Given this list of marker genes UBA52, LIG1, RFC4, RFC3, POLD1, RPA1, XRCC1, UBC, POLE3, POLD4, RPA2, POLK, POLE4 (NCBI Gene Id 56655), RPS27A, PCNA, RFC1 (NCBI Gene Id 5981, replication factor C subunit 1), UBB, POLE, RPA3, POLD2 (NCBI Gene Id 5425), RFC2, POLD3, POLE2, RFC5, LIG3, here is a description of the gene set: Reactome Pathway: Gap-filling DNA repair synthesis and ligation in GG-NER species: Homo sapiens part of: Global Genome Nucleotide Excision Repair (GG-NER) Global genome nucleotide excision repair (GG-NER) is completed by DNA repair synthesis that fills the single stranded gap created after dual incision of the damaged DNA strand and excision of the ~27-30 bases long oligonucleotide that contains the lesion. DNA synthesis is performed by DNA polymerases epsilon or delta, or the Y family DNA polymerase kappa (POLK), which are loaded to the repair site after 5' incision. DNA ligases LIG1 or LIG3 ligate the newly synthesized stretch of oligonucleotides to the incised DNA strand.